The following is a description of a gene set: Human Gene Set: REACTOME_ORGANIC_CATION_ANION_ZWITTERION_TRANSPORT Organic cation/anion/zwitterion transport studied in species Homo sapiens, and this is the list of marker genes: SLC22A7 (solute carrier family 22 member 7), SLC22A12, SLC22A18, SLC22A5, RSC1A1 (regulator of solute carriers 1), SLC22A1, SLC22A3, SLC22A15, SLC22A2, SLC22A6, SLC22A16, RUNX1, SLC22A8, SLC22A4, SLC22A11